The following is a description of a gene set: This event has been computationally inferred from an event that has been demonstrated in another species.<p>The inference is based on the homology mapping from PANTHER. Briefly, reactions for which all involved PhysicalEntities (in input, output and catalyst) have a mapped orthologue/paralogue (for complexes at least 75% of components must have a mapping) are inferred to the other species. part of: Signaling by EGFR electronically inferred by orthology from the curated human pathway studied in species Mus musculus Reactome Pathway: GRB2 events in EGFR signaling, and this is the list of marker genes: Epgn, Grb2, Egfr, Tgfa, Areg, Btc, Hras